Given this list of marker genes DERL1, CRISP1, CARF, EIF4ENIF1, MAGI3, FKBP4, JUN, DAPK1, KNTC1, WNT10B, CDH10 (cadherin 10), ISYNA1, UBR3, XPO1, CCDC65, ERO1B, LHFPL2, BCAP31, ZC3H11A, NRXN3, NAA50, CREM, PPM1D, CASQ2, PPP2R2C, GREB1, ELK3, PNMA1, DAPP1, SHISA6, HSPD1, DENND1B, PSEN1, HDAC4 (histone deacetylase 4), ARHGAP6, RTN1, DAZL, KLHL28, MAP6, DCAF10, LHX3 (NCBI Gene Id 8022), CAMKK2, EIF4A2, MAT2A, IRF2BPL, HSPA8, COL4A6, TLK1, SERPINH1, RFX3, P4HA1, ACTN2, FANCC, NR4A3, MYOCD, MMP16, RORB, G0S2, MAGEH1, TSPAN6, STC1, RGS1, NUFIP2, HCFC1, IGFBP5, MAPK14, CHD2, ADAMTS9, WWP1, HSPA1L, OTX2, H2AZ1, RBPMS, SCAMP1, RORC, JAML, ZFX, MRPS6, ME1, SIX4, GAD1, SYNM, HSPE1, MBNL2, ECEL1, ADAMTS2, PPID, MARCHF10 (membrane associated ring-CH-type finger 10), PKN3, NRF1, DAZ2, ZP3, UNC79 (NCBI Gene Id 57578), CACNA1D, ARL6IP6, TMCC1, ACOT7, SSBP3, CCT3, DNAJB5, SPIN1, LENEP, BCL9, LINC00173, GOT1L1, GRM8, GDPD3, LARP4, PSMD10, CCT8, MEF2C, EDN2, TNPO3, ELAVL4, EIF4G2, HIKESHI, HOXD13, MRPL45, PIP5K1A, RASGEF1A, STIP1, EOMES, SLC25A41, FBLN5, EEFSEC, LUZP1, TMEM71 (transmembrane protein 71), ZNF212, TPM2, CYP46A1, PTHLH, ABCC5, PPT2 (palmitoyl-protein thioesterase 2), FAP, ADCY8, CYLD, USP34, CUX1, CBFA2T3, AMIGO2, OGT, CNTF, PARVB, FOXR1, TSACC, TRERF1, GPR119, CNTFR (ciliary neurotrophic factor receptor), FSCB, ADCY6, ENPP2, TP63, NOB1, TMEM243, SND1-IT1, RPH3AL, ASNS, DNAJA1, TSPAN13, GIGYF1, CCM2, BPIFB1, RBFOX1, RTL9, TSSK3, MORF4L2, RSF1, SLC2A4, EHD1, PLOD1, EFNB3, HSPB2, CUL2, CHST8, CLDN2, NEK6, KCNS2, GRIK1, TYR, ZNF410, ODAPH, JMJD6, NFKBID, JAM3, GSTA5, TMEM131L, ST8SIA1, SMAD1, AHCTF1 (NCBI Gene Id 442770), CACHD1, OSR2, HIVEP2, TSPAN31 (tetraspanin 31), ATP2C1, ZBTB32, PCDH10, IL36RN, ATP1B3, MAPK1IP1L, HOXB5, HTN1, HES1, FSTL3, PNRC1, GLRA3, ELOVL5, HSPA1A, GCH1, TMEM107, HOXB1, ATP1B2, FBXW4, CCT2, SCG2, LAP3, XPNPEP3, DUSP1, SOCS2, TRDN, PAK3, IER5L, VASH1, NFATC3, MDFIC, GPR17, IRF1, SP4, RASGRP2, ZER1, NRN1L, UMODL1, NETO2 (NCBI Gene Id 81831), CCDC126, POPDC3, RUNDC3A, PTGIS, CCT4, PIP5K1P1, KRIT1, SLC36A2, CLEC4D, HSPB1, BNC2, LRP1, ZBTB2, NT5C3A, ID4, PSENEN, MTMR11, IL6ST, MAP2, CSRNP3, NTF4, TFAP2D, ALKBH6, CLASRP, CBX3, CRYAB, WDR12, DDX17, ZBTB20, C12orf50, SEMA3A, PTPRA, CD9, SETD2, CHORDC1, ATL2, CACNA2D2, DMD, BMPR2, COL4A5, HSPB8, IQUB, SYNJ1, SEM1, CYP1A1, LAMTOR3, PLXDC2, FASLG, STAG2, PACSIN3, ANKS1A, EPG5, HNRNPA2B1, NOSIP, GIPC2, NFATC4, ANKRD28, PIP5K1C, SRSF1, NOL4, KANK4, RNF144B, SRP54, HSPH1, POLD4, UBR5, PLXNC1, PARP6, RHBDF2, CTAGE4, ATG4A, NR4A2, CXCR4, IL9, PDE6D, AOC2, EGR3, RGS8, PHF6, BAZ1A (bromodomain adjacent to zinc finger domain 1A), FNDC9, DMRT1, LMTK2, TOMM40L, PLBD1, CCDC140, FLNC, SMYD1, SPAG9, TRPC6, PPP2R5C, TREX1, RSRC2, RALGDS, GPBP1, ST13, MAP4K4, ARHGAP21 (NCBI Gene Id 57584), RBPJ, HSPA1B, CEPT1, AMOT, SHANK1, DND1, U2AF1L4 (U2 small nuclear RNA auxiliary factor 1 like 4), GAD2, DYNC1I2, AAMP, ATP6V1A, NDNF, CISH, SHC3, LMAN2L, LINC00114, TXLNGY, E2F3, HYPK, FXYD2, C1orf116, PSD3, CMTM4, FSIP2, GRM1 (glutamate metabotropic receptor 1), EGF, TRPS1, NFAM1, ADM, HIP1R, BDNF, MIR137HG, C10orf53, PURA, PLEC, ILDR2, TLNRD1, ADAM15, TNFAIP1, EVA1C, GPRASP2, MGLL, STX12, OTP, TPI1P2, ZFAND1, SGF29, AAMDC, ZNF777, SPO11, RAVER1, CHML, DMRTA1, SIDT1, DNAJB1, HCN4, YWHAG, ABCD1, FGF9, NNAT, ANKRD22, C7, PIKFYVE, PRDM12, KRT85, KCNQ1, STARD13, PRDM1, HIPK1, IZUMO1, FHL1, ITGA8, CACNA1A, BRINP3, B4GALT5, LIN37, CHD1, TOGARAM1, DMRTB1, GOLGA2P7, HS6ST3, SLC24A4, HOXB8, TAB2, BCL6, FLT4, LINC00314, TRMT10A (NCBI Gene Id 93587), LRRC8B (NCBI Gene Id 23507), CLVS1, CPA2, RAB6B, GSN, ELF2, PLXNA2, COL6A3, RPRD2, TRIP10, ZNF654, BMP3, DMTF1, FOXP2, MARK3, PAK1IP1, IFT20, SLC35F3, CHST2, SPEN, SCUBE3, PLEKHB1, COL13A1, GNAS, VEZF1, HLA-B, PAX3, ZBTB41, BANF2, DBI, CREBBP, ABHD3, EPHA2, ARMCX3, PNKD, MOBP, RIMS2, AKAP13, VTCN1, GATA3, here is a description of the gene set: Genes having at least one occurrence of the highly conserved motif M68 RGAANNTTC in the regions spanning 4 kb centered on their transcription starting sites. This matches the HSF1 transcription factor binding site V$HSF1_01 (v7.4 TRANSFAC). studied in species Homo sapiens Comprehensive identification of all functional elements encoded in the human genome is a fundamental need in biomedical research. Here, we present a comparative analysis of the human, mouse, rat and dog genomes to create a systematic catalogue of common regulatory motifs in promoters and 3' untranslated regions (3' UTRs). The promoter analysis yields 174 candidate motifs, including most previously known transcription-factor binding sites and 105 new motifs. The 3'-UTR analysis yields 106 motifs likely to be involved in post-transcriptional regulation. Nearly one-half are associated with microRNAs (miRNAs), leading to the discovery of many new miRNA genes and their likely target genes. Our results suggest that previous estimates of the number of human miRNA genes were low, and that miRNAs regulate at least 20% of human genes. The overall results provide a systematic view of gene regulation in the human, which will be refined as additional mammalian genomes become available. from publication Xie X, Lu J, Kulbokas EJ, Golub TR, Mootha V, Lindblad-Toh K, Lander ES, Kellis M (PMID 15735639) Human Gene Set: RGAANNTTC_HSF1_01